Given this list of marker genes SPHK1 (sphingosine kinase 1), GHSR, CSNK2A3, RICTOR, CXCL12 (NCBI Gene Id 6387), RPS6KA1, TAF9B, ZFYVE27, HMGA2, CDH4, CYBA, S100A8, GHRHR, WNT2, PIM1, ACSL4, SMURF1, MAP3K13, GHRH, EXOSC2, GDI1, PROX1, GOLGA4, ZPR1, GHRL, MAPKAP1, CRK, PPM1F (NCBI Gene Id 9647), PPIB (peptidylprolyl isomerase B), MIR19B1, FGF9, STAT5A, BCL11A, TEAD1, NACA, WT1, SRF, GH1, ADAM10, FGFR2, ISLR2, DSCAM, BDNF, PAK1, SEMA7A, MIR208A, MTOR, DNPH1, PLCB1, ACTN3, CSF1, MIR199A1, TBX2 (T-box transcription factor 2), AGR2, CDK1, SYT3, CPNE5, MIR590, UNC13A, SLC9A1, LPAR3, ADNP, MAPK14, SUPV3L1, CPNE9, TGFBR3, VEGFA, ACACB, EXOSC4, CFL1, NIPBL (NCBI Gene Id 25836), MIR19A, EXOSC9, SMAD7, EIF4G1, ARMC12, IL7, HEY2, BASP1, IL2, KLHL22, ARMC10, EXTL3, CDC42, SYT14P1, WFS1, SOX15, SLC44A4, ITSN2, WNT3, CDKL5, SYT2, MAP2K5, NTRK3, BBS4, BMPR1A, KRT17, CAPN3, TRPC5, INO80, CEP43, BBS2 (Bardet-Biedl syndrome 2), MAP1B, CHD7, DDX49, MACF1, RFTN1, H3-5, SEMA5A, NEDD4L, LGI1 (NCBI Gene Id 9211), MIR17HG, MIR204, MIR548C (microRNA 548c), POU3F2, AGRN, NRP1, FGF2, EZR, SASH3, CREB1, S100A9, SFRP2, MEF2C, CDKN2AIP, PUM2, HDGFL2, PARP2, MIR222, MKKS, RPTOR, HYAL1, RIMS2, SLC23A2, MMP14, DLL1, TWF2, CSNK2A1 (NCBI Gene Id 1457), SPTBN4, SYT4, BMPR2, PAFAH1B1, CACNG7, SERP1, AKAP6, TNFRSF12A, F2, RASAL1, NRG1, DDX3X, MTPN, SHTN1, EIF4G2, CACNA2D2, SLC6A3, HOPX, SDCBP, GHR, TRIM32, SYT1, INSR, IGFBP1, RAG2, SLC25A33, PPARD, FGF8, ERBB2, PRKN, MIR509-1, IL9, LIMK1, RNF157, H3-3B, MAPT, WNT3A, NTN1, RUFY3, MLST8, ZFPM2, AVPR1A, EFNA5, NCBP1, VIL1, NGF, CIB1, IST1, GPAM, BRAT1, DRD2, INS, HSF1, PLS1, TBX20, ERBB4, NOTCH1, CD38, MTM1, POU4F2, RPS6KA3, L1CAM, SFN, IGF1, BMP10, STAT5B, PSMD10, RBPJ, RND2, PRR5, KDM2B, HPN, ZNF639, SYT17, AVP, N6AMT1, EGFR, RIMS1, TBX5, H3-3A, SFRP1, MUL1, ADAM17 (NCBI Gene Id 6868), PEX5, TFCP2L1, BCL2, SEMA4D, MFSD2A, ATP8A2, UCN, GLI1 (GLI family zinc finger 1), PABIR1, MYOD1, CXCL16 (NCBI Gene Id 58191), FOXS1, FGFR1, ARX, GATA6, CRABP2, HBEGF, CPNE6, TGFBR1, ANAPC2, ADCY10, PRSS2, PLAA, AKT1, ZP3, DIO3, MEGF8, EDN1, LEP, TRPV2, DISC1, YBX3, IGF2, CCNB1, TGFB2, CRYAA, FN1, DERL2, SMO, YAP1 (NCBI Gene Id 10413), HLX (NCBI Gene Id 3142), GPR21, here is a description of the gene set: species: Homo sapiens Human Gene Set: GOBP_POSITIVE_REGULATION_OF_GROWTH Any process that activates or increases the rate or extent of growth, the increase in size or mass of all or part of an organism.